Given this list of marker genes PDE8B, MAPT, HLA-DQB1, HLA-DRB1, SPART, CHD8, POLG, SETD2, KCNA1, VPS13C, KCNQ2, MAB21L1, CTSH, TNFSF4, ATP6AP2, P2RY11, CWF19L1, PODXL, PRNP (prion protein (Kanno blood group)), FASTKD2, VPS13A, SUPT16H, ATP6V0A2, CA8, TRANK1, NEU1, SCN2A, GALC, GLB1, ATXN1, EZH2, SPG7, ATM, MT-TK, CACNA1A (NCBI Gene Id 773), DARS2, MYORG, HCRT, ZNF365, ABCD1, ACOX2, TBC1D2B, ITPR1, KCND3, MOG (NCBI Gene Id 4340), DPP9, SLC1A3, LINGO1, PIDD1, SYNJ1, ANO10, SPTBN2 (spectrin beta, non-erythrocytic 2), GRIN2A, DNAJC6, here is a description of the gene set: Abnormal coordination of muscles involved in speech. studied in species Homo sapiens Slurred speech Human Gene Set: HP_SLURRED_SPEECH